The following is a description of a gene set: The chemical reactions and pathways resulting in the formation of pyrimidine nucleobases, 1,3-diazine, organic nitrogenous bases. studied in species Homo sapiens Human Gene Set: GOBP_PYRIMIDINE_NUCLEOBASE_BIOSYNTHETIC_PROCESS, and this is the list of marker genes: DHODH, UMPS (NCBI Gene Id 7372), CTPS2, CTPS1, CAD (NCBI Gene Id 790), MTOR, CPS1, CMPK1